Given this list of marker genes LHCGR, ADCYAP1R1, GPER1, PTH, PTH1R, P2RY6, CD244, NTSR1, P2RY1, SNCA, AVPR1B, here is a description of the gene set: Any process that increases the rate, frequency or extent of inositol phosphate biosynthesis. Inositol phosphate biosynthetic processes are the chemical reactions and pathways resulting in the formation of an inositol phosphate, 1,2,3,4,5,6-cyclohexanehexol, with one or more phosphate groups attached. species: Homo sapiens Human Gene Set: GOBP_POSITIVE_REGULATION_OF_INOSITOL_PHOSPHATE_BIOSYNTHETIC_PROCESS